The following is a description of a gene set: Human Gene Set: GOBP_ATRIOVENTRICULAR_NODE_DEVELOPMENT The process whose specific outcome is the progression of the atrioventricular (AV) node over time, from its formation to the mature structure. The AV node is part of the cardiac conduction system that controls the timing of ventricle contraction by receiving electrical signals from the sinoatrial (SA) node and relaying them to the His-Purkinje system. species: Homo sapiens, and this is the list of marker genes: NOTCH2, TBX5, MAML1, GATA4, GATA6, BMPR1A, NOTCH1, NKX2-5, KCNJ8